The following is a description of a gene set: studied in species Homo sapiens Reactome Pathway: Defective OGG1 Localization OGG1 splicing isoform beta contains a mitochondrial targeting sequence at the N terminus and lacks the C terminal nuclear localization signal. OGG1beta localizes to mitochondria, where it might participate in the repair of mitochondrial DNA, although its role in mitochondrial base excision repair has not been confirmed. OGG1beta G12E mutant, reported in kidney cancer, is unable to translocate to the mitochondrion as the missense mutation disrupts the mitochondrial targeting sequence. part of: Defective Base Excision Repair Associated with OGG1, and this is the list of marker genes: OGG1